Given this list of marker genes PRKAG2 (NCBI Gene Id 7981), JPT1, ELAVL4, CRAT, LARP1B, SREBF2, TEC, RND1, USF1, HMGA1, GALR3, ANKRD2, EXOC6, LIMA1, AK9, TMEM35A, RGS8, DGKD, DSCAM, ELAVL3, NPPC, GPR173, CYP26A1, NAA15, SPTB, AGO1 (NCBI Gene Id 26523), ATP1B1, FRMD4A, NLK, CKM, LCN9, EPCIP, ANKHD1, PTPA, CHCHD3, SMARCA5, FEZF2, LRRC8C, IKZF5, RUSC1-AS1, TREX2, POU3F3, B3GALT2, SPOP, NR2E1, GHDC, PTPRJ, PAK3, PSTPIP1, DALRD3, NKX6-2, SELL, ITGA6, RNF220, INHA, GK, SYT4, DCLK2 (NCBI Gene Id 166614), HTR7, ASB15, KCNQ4, PROX1, POLD4 (DNA polymerase delta 4, accessory subunit), RBM26, COL4A3, MAGI1, TJP1, RASGRF2, STARD13, ACADSB, SHCBP1L, DMXL1, NPEPPS, ZIC4, FBXO32, NOL4, UNC45B, NSG2, ALG6, STX4, MID1, FBLIM1, GUCY1A1, DSCAML1, JADE1, ACTN3, KMT2E, EPDR1, STRN3, CDK2AP2, PLCB1, OSR1 (odd-skipped related transcription factor 1), WWC1, TUFT1, CA7, MTUS1, KAZALD1, MANEAL, DOK7, ATOH7, SYNGR1, LURAP1L, ST3GAL5, ITGB4, HR, LINC03124, KCNH2, NEB, ARHGAP36, POLR3GL, GATA2, ARID5A, NDUFAF3, HS6ST3, SLC12A5, DEF6, MYCLP1, ARHGEF2, TBR1, CHRND, SHANK1, EMX1, CASQ1, CCNJL, ELOVL1, LIN28A, MMP11, BEST3 (bestrophin 3), NHLH1, CHRNB1, CELF1, TMEM109, BEX2, CCDC148, PKP4, PHACTR3, XIRP1, SOST, COL4A4, CDH1, USP15, MYLK2, CER1, MAP3K13, PCDH1, NBL1 (NCBI Gene Id 4681), MYCL, CCL20, GGN, ASB14, H2AZ1, CASKIN2 (CASK interacting protein 2), FGF17, NRF1, STK3, CXCR5, FOXI1, IGF2BP1, ARL4A, C2CD2L, SLC26A10P, ABL2, CCNL2, NKAIN2, KCNH5, TAB2, HTN1, GFRA1, PRKACA, GRID2, DMPK, MLLT6, POFUT1, SCG2, USP2, SIPA1, INVS, EFNA1, FBXW11, KCNE5, NCKIPSD, TAC4, TAGAP, AP4S1, NKAIN4, TLK2, JAZF1, TRPV3, DCT, TRIM3, ESRP2, RIN1, VKORC1L1, IGF2-AS, HDAC9, HEYL, GMPR, MAMSTR, ADAMTSL2, HSD11B2, SPI1, BCL9, DPF3, PRKCG, CDON, SSH2, RIMS2, GTDC1, NEDD4L, CRELD1, FUT8, FSCN2, IKZF2, TTN, IGF2, ADAM11, FNDC5, WNT6, TGM1, LRAT, KCNN3, CHRNG, MYOZ3, RHOBTB1, CYRIA, PSMC3IP, PPARGC1A, TNFRSF21, PLAGL2, FIG4, PDGFB, ERBB3, SEMA4C, KRT8, C1orf210, ITPR3, ERBB4, HES6, GNAS, ALG10, ARPP21, TECPR1, ANKHD1-EIF4EBP3, RBPJ, GALNT2, ANK2, GOLPH3L, MDGA1, TSEN54, here is a description of the gene set: studied in species Homo sapiens Human Gene Set: MYOD_Q6 Genes having at least one occurrence of the motif NNCACCTGNY in the regions spanning 4 kb centered on their transcription starting sites. This matches the MYOD1 transcription factor binding site V$MYOD_Q6 (v7.4 TRANSFAC).